Given this list of marker genes EYA1, E2F3, WDFY3-AS2, FBXO30, CLC, PSMD12, TENM3-AS1, LIMK1, CDH23, GABARAPL1, COQ8B, RBBP7, PSMA3, CMAS, FBXO44, SYT2, SLC22A18AS, IL18RAP (interleukin 18 receptor accessory protein), MLEC, HSPA9, NUDT11, ENO3, SH3BGRL2, GSE1, FGF11, PVALB, SEC24D, BAZ2A, FOSL1, LRRFIP2, SNX10, CPA6, EML3, SLC26A1, TLX2, PPP2R2C, DDX17, SPATS2, MFN2, MAP4 (microtubule associated protein 4), S100A2, ARHGAP8, MDFI, LRRC2, CLIC1, PLEKHH3, PFN1, SKP1, P2RX6, CAMKK1, PTPRN, GADD45A, SPTA1, NR1D1, ABCD1, RIT1 (Ras like without CAAX 1), EIF4G1, FGF9, RTN3, ALDOA, FBXO2, DTX2, TUBA4A, MMP9, ADRA1A, ABI3BP, TIAL1, PHLDA2, BLMH, GAST, BNIP3, LYVE1, SLC16A6, TECPR1, CPNE8, CA9, MAPRE3, TENT5B, WDFY3, ABCB6, TTC1, USP13, ANGPTL4, PROCR, DPY19L3, LRP1B, RAB13, XPOT, PRR7, TUBB4A, BAG2 (NCBI Gene Id 9532), SLITRK6, EIF4E, TEX19, ALS2CL, PLBD2 (NCBI Gene Id 196463), ARHGAP32, SFTPC, DTNA, LINC02908, NCDN, AP5B1, ABCA2, MYO10, IL6, NRN1L, ITPKC, MMP19 (NCBI Gene Id 4327), ETV5, DLX1, BTK, TNXB, PLCD1 (phospholipase C delta 1), SEPTIN4, CELA1, LENEP, VAT1, CRYGS, DHRS3, ASS1, SYTL1, VDR, NEFH, TMCC1, MDM2, TINAGL1, NUDT10, MMRN2, CRYBA2, FLT1, PRDM1 (PR/SET domain 1), LINC02694, BACH1 (NCBI Gene Id 571), ZC2HC1C, LAMA3, NECAB3, ZNF771, TUBA4B, SERPINB5, OMG, ENO1, C2CD2L, TLL1, PPP1R9B, NRDC, PSMD11, GSTP1, RELL2 (NCBI Gene Id 285613), GAPDH, ZBTB32, SLC25A51, HS3ST2, DUSP13B (dual specificity phosphatase 13B), ROM1, PAK6, SYNPO, ABHD4, PSMD2, PLEC, HDAC3, CLDN15, MYBPH (myosin binding protein H), MAP2K1, SNCG, PDE4D, OTUD7B, PEA15 (proliferation and apoptosis adaptor protein 15), PPP2CA (protein phosphatase 2 catalytic subunit alpha), AKT3, SMPX (NCBI Gene Id 23676), TUBA1C, ZMAT5, SLC22A18, ABCF3, MT3, RABEP1, CYTOR, PSMD7, RAB3D, SNCB, RB1CC1, CD44, CALB2, PSMD1, AKIRIN2 (akirin 2), GADD45G, PADI4, PALS1, PLS3, SQSTM1, ADAM15, DYNC1H1, IDS, DIRAS1, VASP, here is a description of the gene set: Genes having at least one occurrence of the highly conserved motif M32 TGASTMAGC in the regions spanning 4 kb centered on their transcription starting sites. This matches the NFE2 transcription factor binding site V$NFE2_01 (v7.4 TRANSFAC). Comprehensive identification of all functional elements encoded in the human genome is a fundamental need in biomedical research. Here, we present a comparative analysis of the human, mouse, rat and dog genomes to create a systematic catalogue of common regulatory motifs in promoters and 3' untranslated regions (3' UTRs). The promoter analysis yields 174 candidate motifs, including most previously known transcription-factor binding sites and 105 new motifs. The 3'-UTR analysis yields 106 motifs likely to be involved in post-transcriptional regulation. Nearly one-half are associated with microRNAs (miRNAs), leading to the discovery of many new miRNA genes and their likely target genes. Our results suggest that previous estimates of the number of human miRNA genes were low, and that miRNAs regulate at least 20% of human genes. The overall results provide a systematic view of gene regulation in the human, which will be refined as additional mammalian genomes become available. from publication Xie X, Lu J, Kulbokas EJ, Golub TR, Mootha V, Lindblad-Toh K, Lander ES, Kellis M (PMID 15735639) species: Homo sapiens Human Gene Set: TGASTMAGC_NFE2_01